The following is a description of a gene set: species: Homo sapiens Human Gene Set: REACTOME_LOSS_OF_MECP2_BINDING_ABILITY_TO_THE_NCOR_SMRT_COMPLEX Loss of MECP2 binding ability to the NCoR/SMRT complex, and this is the list of marker genes: GPS2, TBL1XR1, NCOR2, TBL1X, NCOR1, MECP2, HDAC3